The following is a description of a gene set: An anomaly of the nasal base, which can be conceived of as an imaginary line between the most lateral points of the external inferior attachments of the alae nasi to the face. Human Gene Set: HP_ABNORMAL_NASAL_BASE_NORPHOLOGY species: Homo sapiens Abnormal nasal base norphology, and this is the list of marker genes: EXOSC2, SMARCD1, SOX4, SMARCB1, SMARCA2, FIG4, VAC14, SNX14, BCORL1, CTCF, ATP6V1B2, SMARCC2, TBC1D24, SMARCE1, ARID1B, DPF2, ABCA5, MYCN, SMARCA4, ARID2, ARID1A, SLC26A2, SIN3A, KMT5B, LIFR, SOX11, ATP6V1E1, METTL5, MYT1L, USP9X